The following is a description of a gene set: Any DNA replication initiation that is involved in cell cycle DNA replication. species: Mus musculus Mouse Gene Set: GOBP_CELL_CYCLE_DNA_REPLICATION_INITIATION, and this is the list of marker genes: Mcm4, Gins3, Mcm2, Pola1 (polymerase (DNA directed), alpha 1), Mcm3 (NCBI Gene Id 98509)